The following is a description of a gene set: Human Gene Set: REACTOME_ACTIVATION_OF_RAS_IN_B_CELLS species: Homo sapiens Activation of RAS in B cells, and this is the list of marker genes: RASGRP3, HRAS, RASGRP1, KRAS, NRAS